Given this list of marker genes HAUS4, HAUS6, HAUS7, HAUS3, HAUS5, DCTN1, HSPA1B, EML2, HSPA1A, ARHGEF7, PDE4DIP, NME7, CKAP5, MECP2, HAUS1, HAUS8, PAK1, HAUS2, GIT1, here is a description of the gene set: Any process that modulates the rate, frequency or extent of microtubule nucleation. Microtubule nucleation is the 'de novo' formation of a microtubule, in which tubulin heterodimers form metastable oligomeric aggregates, some of which go on to support formation of a complete microtubule. Microtubule nucleation usually occurs from a specific site within a cell. Human Gene Set: GOBP_REGULATION_OF_MICROTUBULE_NUCLEATION studied in species Homo sapiens